Given this list of marker genes LRRC8A, SLC46A2, LRRC8C, LRRC8B, SLC19A1, SHOC2, LRRC8E, LRRC8D, here is a description of the gene set: Human Gene Set: GOBP_CYCLIC_GMP_AMP_TRANSMEMBRANE_IMPORT_ACROSS_PLASMA_MEMBRANE studied in species Homo sapiens The directed movement of cyclic-GMP-AMP from outside of a cell, across the plasma membrane and into the cytosol.